The following is a description of a gene set: Human Gene Set: WP_INTERFERONMEDIATED_SIGNALING Interferon-mediated signaling studied in species Homo sapiens, and this is the list of marker genes: IFNAR1, IFNGR1, IFNGR2, IFNA6, IFNA10, IFNL4, IFNA8, JAK2, IRF9 (interferon regulatory factor 9), IFNK, IFNB1, IFNA7, IFNA21, IFNA4, IFNA1, TYK2, IFNA13, IFNA14, IFNL3, PIK3R1, IFNL2, IFNLR1, IFNW1, STAT1, IL10RB, PRKCA, PIK3CA, IFNG (NCBI Gene Id 3458), IFNA5, IFNL1, IFNAR2 (NCBI Gene Id 3455), IFNA2, IFNA16, IFNE, STAT2, IFNA17, JAK1